The following is a description of a gene set: part of: CHD chromatin remodelers Reactome Pathway: CHD3, CHD4, CHD5 subfamily studied in species Mus musculus electronically inferred by orthology from the curated human pathway This event has been computationally inferred from an event that has been demonstrated in another species.<p>The inference is based on the homology mapping from PANTHER. Briefly, reactions for which all involved PhysicalEntities (in input, output and catalyst) have a mapped orthologue/paralogue (for complexes at least 75% of components must have a mapping) are inferred to the other species., and this is the list of marker genes: H4c11, H2bc3, Sumo1, H3c3, H4c3, H3c7, Mta1, H2bc22, H4c8, H2ac10, H2bc15, H3c1, H2ac8, H4c6, H3c8, H2ac19, H4c14, H3c13, H2ac23, Zfp687, Mbd2, H2bc12, Rbbp4 (retinoblastoma binding protein 4, chromatin remodeling factor), H2bc13 (H2B clustered histone 13), H4c12, H2ac13, H2ac11, H3c15, H4c17 (H4 clustered histone 17), H3c4, H2ax (H2A.X variant histone), H2bc11, H2bc27, H2bc9, Nr2c2, Pwwp2a, H2bc1, H3f3a (H3.3 histone A), H2bc7, Mta2, H3c10, H2ac12, H3c6, H4c2, Rbbp7, H4c18, Mbd3l2, H3c2, H2ac15, Zfp532, H2ac22, H2ac6, H2bc8, H3c11, H2ac1, H4c9, H2az2, H2ac7, H2ac4, H4c1, H2ac20, H2ac24, H4c4, Mbd3